Given this list of marker genes CLDN14, FKBP6, UCN, TNFRSF10C, AANAT, CCDC9, GNG4, FAM131B, SCN2B, EXD2, GAGE12G, NTNG1, S1PR2, MTA2, UNC119B, INHBC, REG1B, S1PR4, KIF21B, DHRS2, LYPD3, L1CAM, WASF2, HMHB1, RIMS2, REN (renin), TRIM15, SLIT3, NR2E3, LORICRIN, HOXB1, EIF4EBP1 (eukaryotic translation initiation factor 4E binding protein 1), GIP, TBXT, ATP4A, SLC7A11 (solute carrier family 7 member 11), ALDOB, HOXC11, CEACAM3, PSCA, CHST1, SLC22A18AS, SPINK2, MAGEC1, LEFTY1, MTHFR, NECTIN1, PPP4R2, KRT32, PTH2R, ASIC3, NSG1, AQP8, DNAJB12, KCTD17, B3GNT3, SLC22A6, ACSL6, RIBC2, SRPK3, SIX3, VAMP1, ENTPD2, CCKAR, CYP2C19, SLC17A3, ABCB9, PTPRN, RASL10A, GAS8, RBMXL2, PRF1, NAT8, TACC2, HCRT, ECE2, GRK1, REPS2, PZP, AMMECR1, DKK4, MYOZ3, SIX6, SEMA7A (semaphorin 7A (JohnMiltonHagen blood group)), MSI1, GREM1, GPR3, BMP10, PGC, SYT5, NDRG2, ADAM20, NRG2, TRPM2, PGAM2, SIT1, TNFRSF6B, AKAP7, CDK5R2, KCND3, CYP27B1, CEP135, NNAT, ALOX15, GNMT, JAKMIP1, ABCC8, TNFRSF13B, KIAA0586, LCE2B, HTR4 (5-hydroxytryptamine receptor 4), SSX4, ADGRL3, LRIT1, MACIR, NELFA, CHRNE, SSTR2, GNG7, ARFGAP3, GFPT2, PRB4, SPC25, BRD4, FLT1, TAGLN3 (transgelin 3), SHBG, SERPINA4, PKP3 (NCBI Gene Id 11187), TEX28, APC2, FAM13A, SCGN, CTSG, ABCA1 (NCBI Gene Id 8371), TRIB1, PI3, SLC7A4, ACTL6B, KCNN1, H6PD, GRIK5, POM121L9P (NCBI Gene Id 29774), CEACAM4, SEZ6L, CLDN9, MAGEA4, PAX7, CHST3, ZNF143, TP63, AKAP3, STATH, CDH1, ZBTB24, TNFRSF21, NR0B2, MET, HSD17B1, IKBKG, SCAMP5, GRM2, H3C6, CDH16, TBX1, MYCL, CCK (cholecystokinin), TRIM10, PRELID3A, TAOK2 (NCBI Gene Id 9344), TFAP2B, AMELX, EMID1, PLIN1, PIGO, P2RX1, MPZL2, RUNDC3A, ATOSB, EDA, CLDN5, FCN2, PTP4A3 (NCBI Gene Id 11156), GALNS, NRXN1, RECQL5, PIGL, ASIP, MYH2, PIK3IP1, NEMF, HBB, NTRK1, SOX10, GALR3, ODF1, CHP2, KCNQ3, ING1, RGS9, MLLT1, MAGEA9, CNTN6, ATP6V1G2, EIF1AY, EXOSC2, IVL, MAGI1, SLC17A7, GLE1, CD4, CRCP, RAC3 (NCBI Gene Id 5881), CCL7, here is a description of the gene set: Genes in the cancer module 242. Human Gene Set: MODULE_242 studied in species Homo sapiens